The following is a description of a gene set: from publication Anderson J, Olafsdottir TA, Kratochvil S, McKay PF, Östensson M, Persson J, Shattock RJ, Harandi AM (PMID 29535712) species: Homo sapiens Systems biology approaches have recently provided new insights into the mechanisms of action of human vaccines and adjuvants. Here, we investigated early transcriptional signatures induced in whole blood of healthy subjects following vaccination with a recombinant HIV-1 envelope glycoprotein subunit CN54gp140 adjuvanted with the TLR4 agonist glucopyranosyl lipid adjuvant-aqueous formulation (GLA-AF) and correlated signatures to CN54gp140-specific serum antibody responses. Fourteen healthy volunteers aged 18-45 years were immunized intramuscularly three times at 1-month intervals and whole blood samples were collected at baseline, 6 h, and 1, 3, and 7 days post first immunization. Subtle changes in the transcriptomic profiles were observed following immunization, ranging from over 300 differentially expressed genes (DEGs) at day 1 to nearly 100 DEGs at day 7 following immunization. Functional pathway analysis revealed blood transcription modules (BTMs) related to general cell cycle activation, and innate immune cell activation at early time points, as well as BTMs related to T cells and B cell activation at the later time points post-immunization. Diverse CN54gp140-specific serum antibody responses of the subjects enabled their categorization into high or low responders, at early ( < 1 month) and late (up to 6 months) time points post vaccination. BTM analyses revealed repression of modules enriched in NK cells, and the mitochondrial electron chain, in individuals with high or sustained antigen-specific antibody responses. However, low responders showed an enhancement of BTMs associated with enrichment in myeloid cells and monocytes as well as integrin cell surface interactions. Flow cytometry analysis of peripheral blood mononuclear cells obtained from the subjects revealed an enhanced frequency of CD56<sup>dim</sup> NK cells in the majority of vaccines 14 days after vaccination as compared with the baseline. These results emphasize the utility of a systems biology approach to enhance our understanding on the mechanisms of action of TLR4 adjuvanted human vaccines. Genes down-regulated in blood 1d vs 0hr in adults (18-45) after exposure to CN54gp140 adjuvanted with GLA-AF, time point 1D, administered i.m. Human Gene Set: ANDERSON_BLOOD_CN54GP140_ADJUVANTED_WITH_GLA_AF_AGE_18_45YO_1DY_DN, and this is the list of marker genes: LASP1, SON, DPP8, MAST3, ZAN, FRA10AC1, RALY, SORL1, ZNF341, DPF2, HNRNPK, SEC23B, ACLY, IDH3B, SPEN, WLS, ARF1, PRRC2C, KMT2D, ARID3A, LAMP1 (lysosomal associated membrane protein 1), STX2, MSN, MIDEAS, CTCF, CREBBP, UBA1, DVL3, TBC1D22A, ACTB, RIC8A, RABGEF1, WAS, HGS, ZNF106, ARHGAP30, BABAM2, ARAP1, MTMR3, ACD, RAB5B, STK24, MAP7D1 (MAP7 domain containing 1), MYH9, CAP1, BANP, FOXJ3, CACNA1S, CBL, ACO2, SAP130, LAPTM5, ADD1, GALNT10 (polypeptide N-acetylgalactosaminyltransferase 10), AFF4, VPS8, TAF4, STK4, YWHAZ, HARS2, CLASP1, ARF3, GRK6, UPF1, ATP6AP1, ARHGAP1, SEC16A, ARPC4, ANTXR2, SRRM1, SH2D3C, FBXL18, PPP1CA, KAT6A, GRK2, DPEP2, GBA1, FLII, ATP6V1B2, RCSD1, PGD, SF3B2, RASSF5, NDRG3, WDR1